The following is a description of a gene set: from publication Amit I, Garber M, Chevrier N, Leite AP, Donner Y, Eisenhaure T, Guttman M, Grenier JK, Li W, Zuk O, Schubert LA, Birditt B, Shay T, Goren A, Zhang X, Smith Z, Deering R, McDonald RC, Cabili M, Bernstein BE, Rinn JL, Meissner A, Root DE, Hacohen N, Regev A (PMID 19729616) studied in species Homo sapiens Human Gene Set: GSE17721_0.5H_VS_8H_PAM3CSK4_BMDC_UP Genes up-regulated in comparison of dendritic cells (DC) stimulated with Pam3Csk4 (TLR1/2 agonist) at 0.5 h versus those stimulated at 8 h. mouse primary BMDCs were stimulated with tlr ligands and gene expression changes were profiled on Affymetrix arrays, and this is the list of marker genes: GLRX3, PLEKHS1, GINS4, SERINC3, PRR15, CD93, CNR2, ZYX, INPP5D, HECTD3, RRM2, RAP1GAP (NCBI Gene Id 9676), AHSA1, RPN1, POLR2G, NPTXR, RIDA, PTPA, CAPN8, TUBGCP3, OGA, ASB4, CSF2RB, DNAJC5, ST7, RAG1, CASQ1, ATMIN, GALK2, MAP3K11, GYS1, ABCB7, SH2D1B, ACBD6, PTTG1IP, SMAP2, MPND, LAMA3, BASP1, HIGD1C, COA6, IGLL1, MRPL15, IFT172, IDNK, NOP16, PDCD6, MIS18A, REXO2 (NCBI Gene Id 51640), AGGF1, BAK1 (BCL2 antagonist/killer 1), EVI5, HLA-E (major histocompatibility complex, class I, E), TSEN34, IFRD2, KLF4, CNP, LYSMD2, NSMCE4A, METAP2, PPP1CA, TF, HAGH, NRDE2, HSP90B1, CD164, MICAL2, SCAMP2, SMAD4, TMA7, ZNF219, PIGX, DNAJC4, MRPS21, MEF2D, SLC12A7, PRAF2, NHSL3, PLEKHF1, PKIB, FNBP1 (formin binding protein 1), QTRT1, ATM, HSD17B10, ANGPTL2, PNPLA7, YIPF1, PTGER2, RNF34, ERMP1, DCAF11, CLEC6A, TRIO (trio Rho guanine nucleotide exchange factor), ATP6V1D, AIPL1, HSPBP1 (HSPA (Hsp70) binding protein 1), TRAF6, C2CD2L, SSBP4, HINT2, PRMT7, PAPSS2, NUFIP1, MIF, LRP1, TRAM1, ATP5MC3 (ATP synthase membrane subunit c locus 3), TALDO1, CCNH, TLE5, C1D, SDC3, SERPINB1, ATP11B, PNPO, SH3BP5L, HNRNPC, INPP5A, ARHGAP31, MBOAT1, BMAL1, SAAL1, TNXB (NCBI Gene Id 7148), FFAR2, COQ9 (NCBI Gene Id 57017), TCEA2, MGMT, BDH1, KLRD1, MAK (NCBI Gene Id 4117), ARL3, CPT1A, RAMP1, SLC66A2, BIN3, DECR1, MFAP1, SDHC, PDHB, GNG10, MRPS9, TMEM160, DNMT1, MARCHF2, EEF1B2, PTPN18, SPRR3, EXOC4 (NCBI Gene Id 60412), EMC3, NIT1, KLF13, TOB1, SCARB2, MRPL48, TMEM141, RBM43, MRC1, ARHGAP23, S100A1, AP1G2, TOM1, DPH7, RABGGTA, PGLYRP1, HAUS4, PTCD2, FABP4, SUMF1, EHD4, ATP5PO, UAP1L1, RASA1, DAP, NDUFB11, ERCC6L, CYTH1, SLC25A51, CENPK, RNASEH2C, TIMP2, TIAM1, CENPB, EXOSC5, MUSTN1, ST6GALNAC4, TMEM131L, SESN1 (NCBI Gene Id 27244), MICOS13, PHACTR2, TNS1, PGLS, ZNF362, COX5A, PYY, PDCD2, NFIL3 (NCBI Gene Id 4783), CPSF3, MDH2, NDUFV2, PRKDC